The following is a description of a gene set: species: Homo sapiens exRNA mechanism of action and biogenesis Human Gene Set: WP_EXRNA_MECHANISM_OF_ACTION_AND_BIOGENESIS, and this is the list of marker genes: DICER1, AGO2, ERI1, DROSHA, DGCR8, XPO5